Given this list of marker genes EFEMP1, ARSG, CCDC28B, BBS1, PRPH2, ARL6, CFH, POMGNT1, TLCD3B, GUCY2D, CFI, CFAP418, GUCA1A, here is a description of the gene set: Human Gene Set: HP_HYPERAUTOFLUORESCENT_MACULAR_LESION Increased amount of autofluorescence in the macula as ascertained by fundus autofluorescence imaging. Hyperautofluorescent macular lesion studied in species Homo sapiens